Given this list of marker genes RAB33B, HOXD13, COL2A1, KAT6A, MATN3 (NCBI Gene Id 4148), CCN6, here is a description of the gene set: Human Gene Set: HP_ENLARGED_INTERPHALANGEAL_JOINTS species: Homo sapiens Enlarged interphalangeal joints